The following is a description of a gene set: species: Homo sapiens Human Gene Set: HP_ULNAR_CLAW An abnormal hand position characterized by hyperextension of the fourth and fifth fingers at the metacarpophalangeal joints and flexion of the interphalangeal joints of the same fingers such that they are curled towards the palm. Ulnar claw, and this is the list of marker genes: EGR2, MPV17, MPZ, NEFL, SBF2, PMP22, HSPB1, GDAP1, PRX